Given this list of marker genes GXYLT1, DENND1B, DISC1, SLC39A13, MDH1B, SP1, FRYL, PPM1E, PPFIA2, UNC80, GPATCH2L, COL27A1, TMEM167A (transmembrane protein 167A), APBA2, UGT8, SLC35F1, HYCC1, NPTXR, OTULIN (NCBI Gene Id 90268), POGLUT1, YAF2, POGZ, ZDHHC17, NFX1 (nuclear transcription factor, X-box binding 1), AKR7A2, MED12L, IL13RA1, SPG21, YWHAB, SH3RF1, GRIA4, ENAH, SAMD12, RO60, COLGALT2, ECE1, VANGL2, ITPKC, DOT1L, RNGTT, COL21A1, RGL2 (NCBI Gene Id 9264), NAV2, SOCS6, RERE, ZNF618, SLC35F3, DCX, FEM1B, TRPV3, MOSPD3, SMAP1, EYA4, SLC39A7, PNKD, PAX9, CSF1, TNFRSF10D, ST6GALNAC3, ABL2, TXNIP, MIEF1, GALNT7 (polypeptide N-acetylgalactosaminyltransferase 7), BEND4, AFF3, RAB11FIP1, KLHDC8A (NCBI Gene Id 55220), MTA3, SLC7A11, IRF4, SEC24A, CSRP2 (NCBI Gene Id 7882), ZNF704, COMMD3-BMI1, LITAF, SH3BGRL2, OPHN1, KCNK10, ADAMTS5, GLRA2, WEE1, ZBTB20, CDS1, MBTD1, TCEA1, ITGA5, DIRAS1, STRN4, CCNC, PRKX, MSL1, HIC1, HOXA5 (homeobox A5), PDPK1, STIM2, GSPT1, SGMS1 (sphingomyelin synthase 1), PHF24, TGFBR1, PDE7B, RNF144A, RSBN1L, USP46, WBP1L, USH2A, GCC2, ZNF800, ELMO1, SREK1, UBR1, RPS6KA5 (NCBI Gene Id 9252), RAB20, PAIP2, NEK2, CTDSP2, MME, EPB41L4A, ZC3H12D, ABCA12, RETREG3, NDST1, LIMK1, STK35 (serine/threonine kinase 35), WNT3A, PPME1, PLAGL2, UBA6, MAPK14, KCNK2, GEM, SASH1, UBE2V1, FAM184A, MSI2, AFF4 (ALF transcription elongation factor 4), NRXN1, SLIT2, KBTBD11, MEGF11, SOCS5, ALDH4A1, SETD7, IGLON5, APOLD1, PTPRT, CLDN18, RETREG1, RHOT2, CEP76, SKA3, DBF4B, MAPKAPK3, UBR5, RNF182, FBXO30, SS18, NRP2, KMT2A, TRIM23, ARHGEF38, PHF6, PTPRQ, NRBF2, PALS2, TET1, RET, CYP39A1, NKX3-1, KAT7, H3-5, ONECUT2, CABLES2, DNAAF6, CECR2, MIER2, COPB2, GIGYF2, ING5, MINPP1, H3-3B, EFR3A, CXADR, ISL1, SH2D3C, IFITM10 (NCBI Gene Id 402778), MTCL2, BAZ2B, STX7, HIP1, CREB1, ARMC8, ZFP36L1, PLCH1, TMC7, PDHX, SNX18, HMBOX1, GTF2A2, USP42, MAPK8IP3, NXT2, KDM3A, PROSER2, LYPD3, SLC39A11, USP49, ATP8A1, MNT, SYT1, SFXN2, CRKL, ARID1B, MTDH, MLLT10 (MLLT10 histone lysine methyltransferase DOT1L cofactor), FBLN5, ROR1, MAP2K7, TTC9, FRMPD3, ANKRD40, ZFHX3, UBE2W, OPA1, SCAI, GPD2, NEUROD6, PDIA5, ZNF84, SMAD9, SSH1, MIPOL1, SPTY2D1, DCC, TTC39B, DCUN1D4, AK2, VPS4B, EPB41L1, SOS1, GREM1, TRIL, WDR7, CA12, ZFP82, PPP4C, PLK2, TMEM30A, DHTKD1, NAA50 (NCBI Gene Id 80218), CKAP4, CCDC92, BICC1, NFIL3, EEF1AKMT4-ECE2, GPAM, UGCG, E2F7, SLC22A23, NEO1, BMI1, REPS1, TTC39A, EPHB2, GAB1, UBE2E2, TNPO1, VEGFC, GAPT, ABHD17C, SEC61A1, SLC26A11, IGSF3, SHTN1, SLC6A1, RCOR3, MTSS2, DNAAF9, CACNG2, FAM177A1, RND3, CACNA2D3, ITCH, HECTD1, LTBP1, SNAP25, DPY19L3, RAP1B, ARHGAP12, CASC3, TPPP, SZRD1, MBOAT2, C1QTNF7, NEURL4, NGFR, CHTF8, WNK1, ERC2, GRIA3 (glutamate ionotropic receptor AMPA type subunit 3), FSD2, INO80D, RASGEF1B, SORL1, LHFPL3, UBN2, HCN4, ARRDC4, KIRREL1, EIF2S2, F3, NEMP2, NREP (NCBI Gene Id 9315), GNS, FXR2, GABBR2, TMTC2, HAPLN1, RELN, TEAD1, DCP1A, RCAN2, GSK3B, B3GNT7, TMEM87A, SPATA17, PTPRB, CDIP1, STK32A, BLTP1, PDE3A, ECE2, DPP10 (NCBI Gene Id 57628), PDS5B, ST14, SAMD10, SEC22A, GLTP (NCBI Gene Id 51228), MATN3, IRS1, CA7, TMEM25, KCNN3, GCNT2, NSD1 (nuclear receptor binding SET domain protein 1), PTPN9, COL5A1, RPS6KB1, UTP15, ATXN10, PLPPR1, MMD, FNDC4, ERLEC1, MYT1, MOSMO, STK24, MED14, ABCB9, DTX4, UBE2N, NALF2, NABP1, SLC5A3, CBLB (NCBI Gene Id 868), SP2, CCNT2, BCORL1, CNTLN, UNC13C, CEMIP, G6PC3, GALNT3, FBLN2 (NCBI Gene Id 2199), ZNF652, CDH24, MTMR4, CA10, VANGL1, PCNX1, FAM78A (family with sequence similarity 78 member A), SLC24A4, RYBP, PITPNM2, BAG2, PDE10A, ADCY2, N4BP1, AKIRIN1, PHB1, ZKSCAN2, GCC1, SAMD9L, PGAP1, MCF2L, CLPP, KDM7A, SOX7, MED13L, CCDC88A, CCN4, RECK, MARK4, OSBPL10, JAG1, RNF38, ARF3, XPR1, GRM5, FOXA3, TMEM64 (NCBI Gene Id 169200), SERTAD2, DPY19L4, SNX12, ASPH, RAB39B (RAB39B, member RAS oncogene family), HYCC2, LBH, FBXW7, CCNK, MET, AK4, SRGAP2, PPP1CC, SIRT1, SMAD2, NUS1, STAG1, RARA, NALF1, AMER2, NRK, SMARCA2, ARHGAP32, GATA6, CNOT6, LPAR6, TUB, STOX2, GRIN2D, AMD1, NF1, PLCL2, MSTO1, ARHGAP21, GRIK3, PTAR1, SCAF11, EML1, C1orf21, MDN1, here is a description of the gene set: species: Homo sapiens Genes predicted to be targets of miRBase v22 microRNA hsa-miR-128-3p in miRDB v6.0 with MirTarget v4 prediction scores > 80 (high confidence targets). from publication Chen Y, Wang X (PMID 31504780) Human Gene Set: MIR128_3P